The following is a description of a gene set: species: Homo sapiens Human Gene Set: MIR219A_1_3P Genes predicted to be targets of miRBase v22 microRNA hsa-miR-219a-1-3p in miRDB v6.0 with MirTarget v4 prediction scores > 80 (high confidence targets). from publication Chen Y, Wang X (PMID 31504780), and this is the list of marker genes: JAK2, MAK16, ERAP1, ZNF117, GPC6, GPR171, RAB9B, IBSP, GLG1, CTNNA3, PDZD2, STXBP4, YBEY, ATP2B1, FEM1C, HECW1, LAMA1, TNRC6B, FBXW10B, MEMO1, NR4A3 (NCBI Gene Id 8013), ST13, REG1A, TRHDE, KCNH7, PAQR3, TFEC, SLC17A6, SNX12, CNTN3, ZNF652, GBP4, ACAT2, MBNL1, MINAR1, EPHA5, SEC24B, SNX31, ANXA8L1, CD83, ANXA8, ARF1, KERA, SLITRK3, PIM1, MDGA2, PABPC4, DYNAP, MTCH2, ZNF197, TTC39C, USP53, DENND1B, KPNA3, ERI1, LINC02909, KCNN3, FASLG, YY1AP1, ELOVL6, SLC10A7, BIRC3